Given this list of marker genes Tank, Bak1, Il1r2, Socs3, Irf3, Irf6, Il10, Tor1aip2, Tlr6, Ifngr1, Socs1 (suppressor of cytokine signaling 1), Lsp1, Il10rb, Irf1, here is a description of the gene set: Mouse Gene Set: WORSCHECH_TUMOR_EVASION_AND_TOLEROGENICITY_DN from publication Worschech A, Kmieciak M, Knutson KL, Bear HD, Szalay AA, Wang E, Marincola FM, Manjili MH (PMID 18381452) We have previously shown T-cell-mediated rejection of the neu-overexpressing mammary carcinoma cells (MMC) in wild-type FVB mice. However, following rejection of primary tumors, a fraction of animals experienced a recurrence of a neu antigen-negative variant (ANV) of MMC (tumor evasion model) after a long latency period. In the present study, we determined that T cells derived from wild-type FVB mice can specifically recognize MMC by secreting IFN-gamma and can induce apoptosis of MMC in vitro. Neu transgenic (FVBN202) mice develop spontaneous tumors and cannot reject it (tumor tolerance model). To dissect the mechanisms associated with rejection or tolerance of MMC tumors, we compared transcriptional patterns within the tumor microenvironment of MMC undergoing rejection with those that resisted it either because of tumor evasion/antigen loss recurrence (ANV tumors) or because of intrinsic tolerance mechanisms displayed by the transgenic mice. Gene profiling confirmed that immune rejection is primarily mediated through activation of IFN-stimulated genes and T-cell effector mechanisms. The tumor evasion model showed combined activation of Th1 and Th2 with a deviation toward Th2 and humoral immune responses that failed to achieve rejection likely because of lack of target antigen. Interestingly, the tumor tolerance model instead displayed immune suppression pathways through activation of regulatory mechanisms that included in particular the overexpression of interleukin-10 (IL-10), IL-10 receptor, and suppressor of cytokine signaling (SOCS)-1 and SOCS-3. These data provide a road map for the identification of novel biomarkers of immune responsiveness in clinical trials. Selected genes with immunologic function which were reciprocally changed in evasion and tolerogenic tumor models. studied in species Mus musculus